Given this list of marker genes Mef2c, Usp19, Adrb2, Mir214, Dll1, Myog, Tgfb1, Twist1, Shh, Myod1, Rps6kb1, Actn3, Tcf7l2, Mtm1, Usp2, Flot1, Shox2, Myf6, Igf2, Hmgcr, Megf10, Ctnnb1, Prkaa1, Wnt10b, Bcl2, Cdon, Myf5, Lmod3 (NCBI Gene Id 320502), Ybx3, Wnt3a, Nras, here is a description of the gene set: Any process that modulates the frequency, rate or extent of skeletal muscle tissue development. studied in species Mus musculus Mouse Gene Set: GOBP_REGULATION_OF_SKELETAL_MUSCLE_TISSUE_DEVELOPMENT